Given this list of marker genes HTR2A, PAH, DDC, HTR7, TPH1, BRD2, SLC6A4, here is a description of the gene set: from publication Dierick HA, Greenspan RJ (PMID 17450142) Genes involved in serotonin function, orthologs computed from D. melanogaster genes using InsParanoid resource. species: Homo sapiens Both serotonin (5-HT) and neuropeptide Y have been shown to affect a variety of mammalian behaviors, including aggression. Here we show in Drosophila melanogaster that both 5-HT and neuropeptide F, the invertebrate homolog of neuropeptide Y, modulate aggression. We show that drug-induced increases of 5-HT in the fly brain increase aggression. Elevating 5-HT genetically in the serotonergic circuits recapitulates these pharmacological effects, whereas genetic silencing of these circuits makes the flies behaviorally unresponsive to the drug-induced increase of 5-HT but leaves them capable of aggression. Genetic silencing of the neuropeptide F (npf) circuit also increases fly aggression, demonstrating an opposite modulation to 5-HT. Moreover, this neuropeptide F effect seems to be independent of 5-HT. The implication of these two modulatory systems in fly and mouse aggression suggest a marked degree of conservation and a deep molecular root for this behavior. Human Gene Set: DIERICK_SEROTONIN_FUNCTION_GENES